Given this list of marker genes Egln1, Cyp2w1, Trf, Nfu1, Alox5, Cdo1, Fto, Cyp8b1, Cyp46a1, Ch25h, Cyp4a14, Ltf, Miox, Cyp3a25, Aco2, Alox12e, Aox2, Iscu, Dohh, P3h2, Fthl17b, Fech, Cisd1, Ftl2-ps, Cyp2c70, Cyp11a1, Cyp26b1, Alkbh8, Ciapin1, Fthl17d, Cyp3a13, Fth1, Cyp2f2, P4ha1, Cyp19a1, Isca2, Haao, Kdm7a, Fthl17c, Cyp4f18, Cyp1a1 (cytochrome P450, family 1, subfamily a, polypeptide 1), Abce1, Phf2, Lcn2, Tph2, Cyp39a1, Ogfod2, Alox12b, Cyp7b1, Cyp4a12b, Cyp2j6, Cygb (cytoglobin), Hba-x, Cyp4a12a (cytochrome P450, family 4, subfamily a, polypeptide 12a), Dpyd, Alox15, Dph3, Cyp2c39, Ppef1, Jmjd6, Cyp26c1, Tet1, Acp5, Cyp2a5 (NCBI Gene Id 13087), Agmo (alkylglycerol monooxygenase), Fa2h, Scd1, Plod2, Cyp24a1, Cyp7a1, Cyp2d10, Cyp2c55, Cyp2c54, Cyp3a16, Cyp3a11, Cyp4v3, Aox4, Msmo1, Kdm3a (lysine (K)-specific demethylase 3A), Calr, Cyp27a1, Adi1, Alox8 (arachidonate 8-lipoxygenase), Dnajc24, Cyp4b1, Cyp2c50, Hba-a1, Egln3, Egln2, Scd4, Cyp1a2, Cyp4a10, Cyp2s1, Ftmt, Sc5d, Th, Cyp4f14, Ogfod3, Ppp1ca, Ogfod1, Inhca, Alkbh1, Fthl17e, Cyp51, Cyp17a1, Ethe1, Plod1, Alkbh2, Ftdc1, Cyp2b10, Tbxas1, Tet2, Bbox1, Fthl17f, Cyp2d26, Cyp2r1, Cyp21a1, Hpd (NCBI Gene Id 15445), Ftl1, Cyp2a12, Hif1an, Cyp2e1, Fthl17a, Ftl1-ps2, Alox12, Plod3, Scd2, Rplp2, Phf8 (NCBI Gene Id 320595), Pah, Cyp11b2, Cyp2c23, Cyp4x1, Cyp2c37, Alkbh3, Aox1, Cyp2c29, Fdx1, Phyh, Cyp2d9, Cyp2a4, Rplp2-ps1, Scd3, Cyp1b1 (NCBI Gene Id 13078), Nt5e, P4ha2 (procollagen-proline, 2-oxoglutarate 4-dioxygenase (proline 4-hydroxylase), alpha II polypeptide), Ado, Cyp2b19, Cyp2c38, Cyp2j5, Urod, Aloxe3, Ptgis, Cyp2d11, Meltf, Fbxl5, Riox1, Ppef2, Cyp2u1, P4ha3, Cyp2b9, P3h3, Rrm2, Cyp27b1 (cytochrome P450, family 27, subfamily b, polypeptide 1), Snca, Ftdc2, P3h1, Heph, Slc11a2, Tyw5, Fxn, Xdh, Cyp20a1, Aox3, P4htm, Cyp26a1, Tph1, Cyp2c40, here is a description of the gene set: Mouse Gene Set: GOMF_IRON_ION_BINDING studied in species Mus musculus Binding to an iron (Fe) ion.